Given this list of marker genes Psma3, Numb, Psmb4, Psmc5, Psmd7, Psmc4, Ubb, Psmc1, Psma7, Psmb6, Psmb7, Psmc6 (NCBI Gene Id 67089), Cul1, Psma1, Rps27a, Psma4, Psmd12, Psma2, Psmb5, Psmd6, Psma5, Psmc2, Psmd13, Psma6, Psmd1, Psmc3, here is a description of the gene set: part of: Hedgehog 'off' state Reactome Pathway: Degradation of GLI1 by the proteasome studied in species Mus musculus This event has been computationally inferred from an event that has been demonstrated in another species.<p>The inference is based on the homology mapping from PANTHER. Briefly, reactions for which all involved PhysicalEntities (in input, output and catalyst) have a mapped orthologue/paralogue (for complexes at least 75% of components must have a mapping) are inferred to the other species. electronically inferred by orthology from the curated human pathway